The following is a description of a gene set: Genes in the cancer module 3. species: Homo sapiens Human Gene Set: MODULE_3, and this is the list of marker genes: MCM2, TRAM2, SLC25A1, EFEMP1, ENG, MAPRE1, GGH, QSOX1, CALCRL, PTTG1, MTHFD1, RRP1B, ANXA1, RRM2, CTNNAL1, MRPL3, WDR45B, FOXM1, MAP4K4, TGM2 (NCBI Gene Id 7052), CCNF, NOLC1 (nucleolar and coiled-body phosphoprotein 1), F2R, ELF4, ABCF1, NDUFS6, TM4SF1, SLC4A2, SRP19 (NCBI Gene Id 6728), BOP1, CCND3, TSPAN3, CYB5B, TPM1, PSMD7, ITPR3, TMEM106C, EPB41L3, UBE2C, CAV2, SUZ12, TYMS (thymidylate synthetase), ALCAM, MRPL47, IRAK1, EPHA2, MCM5, STEAP1, SOX4, CDKN1A, CASP4, MTUS1, SRP54, LMNB1, CDC25B, DNMT1 (DNA methyltransferase 1), RCC1, UBN1, CCT6A, CNN3, ADGRG6, TRIP6, COL4A1, PPP4C, MCM6, ACTR2, MAD2L1, SRSF2, ZWINT, NNMT, MBNL1, UBE2J1 (ubiquitin conjugating enzyme E2 J1), CD44, IPO7, PAICS, H4C3, SLC39A7 (NCBI Gene Id 7922), CALU, SMC4, TOMM34, MSMO1, MAPK6, RND3, MCFD2, KRT7, TNPO1 (NCBI Gene Id 3842), COL2A1, PSMC6, BTG3, GYG1, BIRC2, KRT4, SNRPC, GJB1, SMTN, SWAP70, PSMG1, UBE3C, PLK1, PES1 (pescadillo ribosomal biogenesis factor 1), PLOD2, UBE4A, RRM1, MYBL2, AP1M1, COX7B, GJA1, LOX, TOMM40, RAB11A, PSMD14, ZKSCAN3 (NCBI Gene Id 95379), TWF1, NHP2 (NHP2 ribonucleoprotein), ITGB5, PDLIM5, STMN1, ACTN1, FERMT2, GALNT1, APOBEC3B, ANXA3, PTP4A1, CD151, FADS2, SMARCA4, RHOG, GRN, SQLE (NCBI Gene Id 6713), PDGFA, MEST, METAP1, TK1, CCL2, TFRC, LOXL2, CBX3, VAT1, AIMP2, VDAC2, PSMC2, VBP1, CDK1, SNRPF, PLAUR, SRGN (serglycin), DDX3Y, ADAM9, PLK3, CD55, MFAP2, CCNB1, TPX2, FADD, CENPA, COPS2, ANPEP, HNRNPA0 (NCBI Gene Id 10949), APEX1, NQO1, GMFB (glia maturation factor beta), DAB2, SNRK, RAC2, LSM2, PCBD1, PON2, EEF1E1, UBE2M, SEC11A, STAU1, FST, CDV3, COPS5, MYO10, UGCG, ALDH1A1, SCHIP1, APRT, CAD, MAFF, TNFRSF10B, LTBP2, CAVIN1, LAPTM5, LSM1, SGK1, TOP2A, EIF3I, TGFBR2, DLGAP5, EXTL2, LAMB1, EPAS1, CBX1, IGFBP4, GNG12, LMNB2, BMP4, SLC16A3, UAP1, UCK2, RCN1, PECAM1, PGF, DEGS1, RAB13, DBN1, VAMP5, MMP1, NUP205, SFXN3, WWTR1, FHL2, FLNA, CDC42EP1, TMX1, RBBP7, RALA, SEC13, SMURF2, IARS2, HPRT1, ECHS1, PPP5C, SLC7A5, CCNG1, GMPS, MBD4, DDX1, TPM2, DDX21, HSPG2, GBE1, IMMT, ACAT2, HOMER3, PTX3, RGS5 (NCBI Gene Id 8490), FSTL1, MGLL, CDKN3, PCLAF, DNM2, SH3GL1 (NCBI Gene Id 8179), PRPSAP1, PALM2AKAP2, SEMA6C, CDC123, LPCAT1, PLIN2, PSMC4, KIFC1, CAV1, PLS3, SHMT2 (NCBI Gene Id 6472), EMP1, GDF15 (growth differentiation factor 15), PPP4R1, PHLDA2 (pleckstrin homology like domain family A member 2), DUSP6, SLC29A1, ITGA5, VWF, H2AX, CYFIP1, PDLIM4, FGFR1, ARHGDIB (NCBI Gene Id 397), IQGAP1, CCND1, PIR, ARPC1A, FN1, ITGA6, DHX9, RO60, MICAL2, CDK2, MRPL12, PSMA3, S100A11, PSMB7, ANXA2, CKS2, FDPS, EWSR1, FEN1, IGF2BP3, LSM3, MCM3, DTYMK, ATIC, PDLIM7, SCP2, IGFBP2, TFDP1, KIF11, DAP3 (NCBI Gene Id 7818), AKAP12, SLC1A5, PTPRK (protein tyrosine phosphatase receptor type K), DUSP14, TARBP2, YWHAE, PRSS23, HSF1, PTPN12, CDC20, GSPT1, DPYSL3, PSMD4, ZDHHC3, POLE3 (NCBI Gene Id 54107), THBS1, CHAF1A, CCNA2, SERPINH1, IER3, EMP3, TFPI, SSR1, RAB5C, RCN2, PLXND1, ESM1, CLTC, ZYX, LDLR, EIF4EBP1, SSBP1, SEC23A, HSD17B10, IFI16, DLC1 (NCBI Gene Id 94517), CTSC, SRPX, SNRPB2, PNP, NAP1L1, CRIM1, EBP, NDUFA9 (NCBI Gene Id 4721), ACOT7, STAB1, BUB1B, ILF3, GNG11, CITED2, RPA1, TRIP13, SERPINE1, FADS1, RGS4, MLLT11, KRT18, TMED3, FLII, MCM7, CCN1 (cellular communication network factor 1), ERF, MDK, AURKB, PLK2, UNG, PSMA4, INSIG1, PRPF19, CALD1, CCNB2, RAC3, POLD2, STK25, CSE1L, PCNA, CDH2, PKIA, LPIN1, BYSL, SMAD3, FDFT1, COPS3, PROCR, NDUFS2